Given this list of marker genes SERPINB12, CFL2, PRDM12, ADCYAP1, SLC25A23, MYLK, here is a description of the gene set: Human Gene Set: MIR1204 species: Homo sapiens from publication Chen Y, Wang X (PMID 31504780) Genes predicted to be targets of miRBase v22 microRNA hsa-miR-1204 in miRDB v6.0 with MirTarget v4 prediction scores > 80 (high confidence targets).